The following is a description of a gene set: species: Mus musculus Mouse Gene Set: GOBP_CORTISOL_SECRETION The regulated release of cortisol, a steroid hormone that in humans is the major circulating hormone of the cortex, or outer layer, of the adrenal gland., and this is the list of marker genes: Ghrl, Galr1, Gal, Crh (corticotropin releasing hormone), Ptpn11